The following is a description of a gene set: species: Homo sapiens Human Gene Set: MIR6851_3P from publication Chen Y, Wang X (PMID 31504780) Genes predicted to be targets of miRBase v22 microRNA hsa-miR-6851-3p in miRDB v6.0 with MirTarget v4 prediction scores > 80 (high confidence targets)., and this is the list of marker genes: AFF4, ITGA5, DAPL1, FOXO4, DDB2, GTPBP2, KIAA0408, HAPLN1, ADGRF5, EN2, SOX11, RBFOX1 (NCBI Gene Id 54715), IVD, NAA15, ZFP91, NKX3-1, RIMBP2, EIF2AK2 (NCBI Gene Id 5610), GPM6A, RALA, CNR1, VMP1, SERPINB1, PLPPR2, NR3C1, PLCE1 (NCBI Gene Id 51196), GDAP2, ZNF367, CYB561D1, SCN2B, CHST7 (carbohydrate sulfotransferase 7), B3GALT1, ZNF518B, ZNF131 (zinc finger protein 131), STRADA, SMPD1, MTCL3, C16orf87, PTPN9, IPO11, TNR, SNRK, SLC4A9, TCF7L2, KCNH2, FAM133B, PGM2, H2AX, SIX4, PPP3CC, PLCB1, CNOT2, KDM7A, GTDC1, IL9R (interleukin 9 receptor), REST, SERTAD2, EDARADD, ADAM19